The following is a description of a gene set: species: Homo sapiens Dendritic cells (DCs) and macrophages (MPs) are important for immunological homeostasis in the colon. We found that F4/80hi CX3CR1hi (CD11b+CD103-) cells account for 80% of mouse colonic lamina propria (cLP) MHC-IIhi cells. Both CD11c+ and CD11c- cells within this population were identified as MPs based on multiple criteria, including a MP transcriptome revealed by microarray analysis. These MPs constitutively released high levels of IL-10 at least partially in response to the microbiota via an MyD88-independent mechanism. In contrast, cells expressing low to intermediate levels of F4/80 and CX3CR1 were identified as DCs, based on phenotypic and functional analysis and comprise three separate CD11chi cell populations: CD103+CX3CR1-CD11b- DCs, CD103+CX3CR1-CD11b+ DCs and CD103-CX3CR1intCD11b+ DCs. In non-inflammatory conditions, Ly6Chi monocytes differentiated primarily into CD11c+, but not CD11c- MPs. In contrast, during colitis, Ly6Chi monocytes massively invaded the colon and differentiated into pro-inflammatory CD103-CX3CR1intCD11b+ DCs, which produced high levels of IL-12, IL-23, iNOS and TNF. These findings demonstrate the dual capacity of Ly6Chi blood monocytes to differentiate into either regulatory MPs or inflammatory DCs in the colon, and that the balance of these immunologically antagonistic cell types is dictated by microenvironmental conditions. Human Gene Set: GSE27859_MACROPHAGE_VS_CD11C_INT_F480_HI_MACROPHAGE_UP Genes up-regulated in macrophages versus those sorted as ITGAX int and EMR1 high. from publication Rivollier A, He J, Kole A, Valatas V, Kelsall BL (PMID 22231304), and this is the list of marker genes: CPEB4, REPS1, TCEA1, PPP1R15B, IKBKE, ING1, ANAPC10, MITF, SFXN1, PCGF3, EXT1, PARP14, TNF, TRIM75, LARP4B, SNX18, APBB1IP, ACTN1, GSR, PWP1, CEMIP2, RLIM, MAN2A1, GBP5, VASP, MIR222, TTC39C, SOWAHC, GFI1, TOR1AIP2, NOD1, PPP1R15A, TREX1, MIR130B (NCBI Gene Id 406920), PARP8, GADD45B (growth arrest and DNA damage inducible beta), FOXP4, GBP3, FBRS, KDM6B, MTDH, MYO6 (NCBI Gene Id 4646), FBXL3, TMX3, RAB38, SORT1, CD69, PTF1A, PLAGL2, XKR8, PMPCA, GRAMD1A, G3BP1, SLC30A6, YJU2B, NAA25, PDE1B, NR1H3, GCA, MST1, APPBP2, RASA4, SLA, SNX10, IL23A, SLC25A25 (NCBI Gene Id 114789), MCTP1 (NCBI Gene Id 79772), SMCR8, CD44, ATOH1, CRY1, PTP4A1, ADORA2B, PHLDA1, NFKB1, LZTFL1, PELI1, NRG4 (NCBI Gene Id 145957), WDR59, NOD2, FGFRL1, NFKBIA, MRPL32, PGPEP1, MALT1, STK3, EEIG2, PSMD11, C16orf89, TRIOBP, TASOR2, PIK3AP1, PPARG, TICAM2, UBAP1, RAB12, TMC2, PLEK, ETF1, PTPN23, TENT4A, RRS1, MAP2K4, CCNL1, UBE2J2, KPNA3, BDP1, ABL2 (ABL proto-oncogene 2, non-receptor tyrosine kinase), CRLF3, TRIM13, TANK, IRAK2 (interleukin 1 receptor associated kinase 2), CTPS1, RELB, GGCT (gamma-glutamylcyclotransferase), NR6A1, CENPH, RBM7, SPATA13, SLC16A10, RELA, TNFAIP2, TNFSF15, TSHB, HEATR6, GSPT1, CAV1, RCL1, DAAM1, DOCK5, NCK1, RAB11FIP1, NLRP3, COP1, MX1, PRPF40A, TLK2, SRI, DUSP16, RMDN3, METTL6, MAP3K8, MMADHC, MFSD14B, MAPK8, PTPN12, HINFP, TOMM20, CRK, IFI16, LCP2, DYRK2, GPD2, ATF3, NRF1, SBDS, RFFL, RDH11, ARF4, NFKBIE, NLRC4, FOXN2, CCDC88B, PAK1IP1, EHD1, PDE4B, KCNG3, IRF1, VPS37A, DLD, PLEKHO2, TREML4, PPP6C, ICOSLG, MARCKSL1